The following is a description of a gene set: Human Gene Set: GOBP_DENDRITE_EXTENSION studied in species Homo sapiens Long distance growth of a single dendrite involved in cellular development., and this is the list of marker genes: WASF1, CPNE9, CACNG7, SYT4, SYT3, CYFIP1, SMURF1, BCL11A, CDKL3, OSTN (NCBI Gene Id 344901), CPNE6 (copine 6), SH3GL2, MUL1, RNF157, STK11, SLC9A6, CYFIP2, SYT2, AUTS2, SYT14P1, ATG16L1, RASAL1, TMEM108, UNC13A, NEDD4L, PLAA, SYT1, SLC23A2, SYT17, SPAG9, ITSN2, RIMS2, CPNE5, LLPH, PRKN, RIMS1